Given this list of marker genes Dhx29, Dhfr, Patl1, Pcbp1, Cpeb4, Shmt1, Patl2, Cpeb3, Pura, Rack1, Fmr1, Larp1, Rpl10-ps3, Mif4gd, Bc1, Paip1, Eif4ebp1, Serbp1, Ireb2, Tyms, Mirlet7g, Aire, Zcchc13, Dapl1, Cyfip1, Rara, Cpeb1, Rps27l, Samd4, Abcf1, Cirbp, Prkch, Cnbp, Fxr1, Rps9, Ifrd2, Rpl10, Mir9-1, Igf2bp2, Boll, Paip2b, Dazl, Samd4b, Ctif, Rps14, Trim71, Paip2, Eif4ebp2, Ybx2, Igf2bp1 (NCBI Gene Id 98709), Mir135a-1, Nanos1, Purb, Fxr2, Eif2ak3, Cpeb2, here is a description of the gene set: species: Mus musculus Any molecular function involved in the regulation of initiation, activation, perpetuation, repression or termination of polypeptide synthesis at the ribosome. Mouse Gene Set: GOMF_TRANSLATION_REGULATOR_ACTIVITY